The following is a description of a gene set: Scavenging of heme from plasma Human Gene Set: REACTOME_SCAVENGING_OF_HEME_FROM_PLASMA studied in species Homo sapiens, and this is the list of marker genes: IGLC2, IGHV3-13, IGLV3-1, ALB, IGHV1-69, CD163, IGHV2-70, IGKV1-33 (NCBI Gene Id 28933), IGKV2-30 (NCBI Gene Id 28919), IGKV1-17, IGLV1-51, APOL1, HP, IGHV3-53, IGHV3-11, IGLV3-27 (immunoglobulin lambda variable 3-27), IGLV3-21, IGHV3-48, IGKV1D-16, IGHV1-2, AMBP, IGHV2-5, IGKV3-11, IGKV2D-40, IGKV1D-39, IGKV2-28, HBA1, IGKV1D-33, HPR (haptoglobin-related protein), IGLV2-23, IGKV3-15, IGHA2, IGLV3-19, IGHV3-30, IGKV1-39, IGLV2-8, IGLV1-44, APOA1, IGKV5-2, IGHV1-46, IGKV2D-30, IGLV1-47, IGHV4-34, IGHV4-39, IGHV4-59, IGKV3D-20, IGHV3-23, IGKV1-12, IGLC3, IGKV1-5, IGKV2D-28, IGHV3-33, IGKV4-1, HPX, IGHV3-7, IGHA1, IGKV1D-12, IGLV6-57, IGLV1-40, HBA2, IGLV2-14, JCHAIN, IGKV3-20, IGLV3-25, IGLV2-11, IGKV1-16, LRP1, IGLV7-43, HBB